The following is a description of a gene set: Human Gene Set: GCM_MAP4K4 studied in species Homo sapiens Neighborhood of MAP4K4 Neighborhood of MAP4K4 mitogen-activated protein kinase kinase kinase kinase 4 in the GCM expression compendium, and this is the list of marker genes: ATRN, HIPK1, GOLGA7, TMEM30A, EIF4ENIF1, DTNA, ZNF565, TBC1D10B, CRKL, MAP4K4, PHAX, CEP350, CLDND1, ABI2, AGPAT4, STX12, CLIP3, TNS2, ZFP14, KIDINS220, CHST10, ANKS1B, TSPYL4, NPTN, GBA2, NACC1, TSNAX, UBE2H, ERBIN, FAN1, RAN, SH2B1, AHCYL1, UBE2K, FAM168B, PEAK1, FADS1, DZIP3 (DAZ interacting zinc finger protein 3), WSB2, CLASP2, TAFA5, CCDC92, PTK2, MARF1, SIRT2, DYNC1I2, ABHD6, PDE4DIP, MACF1, MYO9A (myosin IXA), RAPH1, AIDA, YWHAG, OCIAD1, DYNC1H1, ZNF275, RNF141, IPO7, POGZ, PHF10, SCD5, IPO5, TNKS, MFSD8, ANKFY1, DNAJB14, TTL (NCBI Gene Id 150465), GOLM2, ARL8B, TJAP1, FAM219A, PDZD2, TNIK, DDHD2, NAA30, PHLPP2, APPBP2, BMPR2, SPIRE1, RAB22A, ATMIN, ZFAND3, TBCK, KDM3B, POMT2, LRRC8A, USP46, NAPG, FBXW11, EPB41L2, TMOD2, BTRC, NGRN, MAPK8IP3, SIK3, LANCL1, VPS52, HIPK2, PACS2, PLEKHB1, ANKRD17, APC2, BLTP1, RTN4 (reticulon 4), CALM1, SNX27, FRYL, WSB1, SAP30L, ULK2, SPAG9, GPM6B, FMNL2, ADO, CLEC16A, TANC2, SLC18B1, GZF1, MTMR4, ZNF404, RNF13, GPRC5B, IL17D, PITPNC1 (phosphatidylinositol transfer protein cytoplasmic 1), UBL3, ZNF84, TTYH2, GLTP, OAZ2, MTMR2, RALGAPA1 (Ral GTPase activating protein catalytic subunit alpha 1), MYO10, ARNT2, DDX17, LRP4, KIF1B, ZNF710, ZEB2, DCUN1D4, HMBOX1, SELENOI, PSAT1, RABL2B, GPR107, GORASP1, PREX1, HERC2, DYNC1LI2, RMDN3, CLCN3, SH3GLB1, DLG1, PTPRD, IL6ST, CCDC88A, PPIG, TRIM37, WBP2, GAB2, RASSF3, ARHGAP21, MTUS1, ACTRT1, BBS2, FBXO21, RDX, SLAIN1, PREPL, SCAMP5, C1orf198, SESN3, C2CD3